Given this list of marker genes Ifit1, Isg15, Ifitm3, Bst2, Grn, Oasl2, Irf7, Faf1, Zbp1, Ifi47, here is a description of the gene set: Mouse Gene Set: CUI_MAST_CELL_IFNK_RESPONSE_UP Cytokines mediate cell-cell communication in the immune system and represent important therapeutic targets. A myriad of studies have highlighted their central role in immune function, yet we lack a global view of the cellular responses of each immune cell type to each cytokine. To address this gap, the authors created the Immune Dictionary, a compendium of single-cell transcriptomic profiles of more than 17 immune cell types in response to each of 86 cytokines (>1,400 cytokine-cell type combinations) in mouse lymph nodes in vivo. A cytokine-centric view of the dictionary revealed that most cytokines induce highly cell-type-specific responses. For example, the inflammatory cytokine interleukin-1β induces distinct gene programmes in almost every cell type. A cell-type-centric view of the dictionary identified more than 66 cytokine-driven cellular polarization states across immune cell types, including previously uncharacterized states such as an interleukin-18-induced polyfunctional natural killer cell state. from publication Cui A, Huang T, Li S, Ma A, Pérez JL, Sander C, Keskin DB, Wu CJ, Fraenkel E, Hacohen N (PMID 38057668) studied in species Mus musculus Genes positively differentially expressed in cell type: Mast cell upon treatment with cytokine: IFN-κ in mouse lymph nodes in vivo.